Given this list of marker genes Adam17, Tmc8, Tnfrsf1a, Traf2, A2m, Tnfrsf1b, Mmp8, here is a description of the gene set: Mouse Gene Set: GOMF_TUMOR_NECROSIS_FACTOR_BINDING species: Mus musculus Binding to tumor necrosis factor, a proinflammatory cytokine produced by monocytes and macrophages.